The following is a description of a gene set: Mouse Gene Set: GOBP_CYTOCHROME_COMPLEX_ASSEMBLY species: Mus musculus The aggregation, arrangement and bonding together of a cytochrome complex. A cytochrome complex is a protein complex in which at least one of the proteins is a cytochrome, i.e. a heme-containing protein involved in catalysis of redox reactions., and this is the list of marker genes: Cox14, Smim20, Uqcc6, Tmem223, Coa3, Uqcrc1, Slc25a33, Cox16, Cox10, Ttc19, Sco1, Cox15, Uqcc1, Cep89, Cox20, Lyrm7, Taco1, Cox17, Coa6, Uqcc2, Cox18, Surf1, Coa4, Cox19 (NCBI Gene Id 70066), Timm21, Uqcc4, Coa7, Sco2, Coa5, Stmp1, Hccs, Uqcc3, Fastkd3, Pet117, mt-Co3, Slc25a46, Cyba (NCBI Gene Id 13057), Pet100, Uqcc5, Bcs1l, Coa8 (NCBI Gene Id 73501)